The following is a description of a gene set: Mouse Gene Set: GOBP_POSITIVE_REGULATION_OF_INTERLEUKIN_8_PRODUCTION Any process that activates or increases the frequency, rate, or extent of interleukin-8 production. species: Mus musculus, and this is the list of marker genes: Lbp, Syk, F3, Ffar2, Lep, Serpine1, Cd244a, Cd14, Adipoq, Ptger4, Nos2, Tnf, Tirap, Park7, Afap1l2, Hmgb1, Lamtor5, Chi3l1, Nod1, Ripk1 (receptor (TNFRSF)-interacting serine-threonine kinase 1), Fcna, Prkd2, Fadd, Rigi (NCBI Gene Id 230073), Clec7a, Cd2, Tlr7 (toll-like receptor 7), Hspa1b, Elane, Fcnb, Tlr3, Pycard, Gdf2, Mavs, Prg3, Il1b, Il6, Zfp580, Myd88 (NCBI Gene Id 17874), Camp, Ddit3, Il17d, Tlr9, Hyal2, Tlr1, Wnt5a, Tlr5, Cd74, Nlrp10, F2r, Tlr2, Il18, Tlr4, Apoa2, Rab1a, Tlr8, F2rl1, Bcl10 (NCBI Gene Id 99555), Rela (v-rel reticuloendotheliosis viral oncogene homolog A (avian)), Nod2, Stat3